The following is a description of a gene set: Mouse Gene Set: SHIN_B_CELL_LYMPHOMA_CLUSTER_8 Aside from Myc-activating translocations characteristic of plasmacytomas (PCT), little is known about genetic factors and signaling pathways responsible for the development of spontaneous B-cell lineage lymphomas of mice. Here, we characterized the transcriptional profiles of PCT, centroblastic diffuse large B-cell lymphomas (CBL), and high-grade splenic marginal zone B-cell lymphoma (MZL++) using high-throughput quantitative reverse transcription-PCR. Expression profiles of CBL and MZL++ were strikingly similar and quite unlike that of PCT. Among the genes expressed at significantly higher levels by PCT were a number involved in NOTCH signaling, a finding supported by gene set enrichment analyses of microarray data. To investigate the importance of this pathway, NOTCH signaling was blocked in PCT cell lines by treatment with a gamma-secretase inhibitor (GSI) or transduction of a dominant-negative mutant of MAML1. These treatments resulted in reduced expression of NOTCH transcriptional targets in association with impaired proliferation and increased apoptosis. GSI treatment of transformed plasma cells in a primary PCT also induced apoptosis. These results integrate NOTCH activation with oncogenic signaling pathways downstream of translocated Myc in the pathogenesis of mouse PCT, two signaling pathways also implicated in development of human multiple myeloma and T-cell lymphoblastic lymphoma. species: Mus musculus from publication Shin DM, Shaffer DJ, Wang H, Roopenian DC, Morse HC 3rd (PMID 19010892) Cluster 8 of genes distinguishing among different B lymphocyte neoplasms., and this is the list of marker genes: Cd38, Nfkbia, Smad7, Tyrobp, Spi1 (NCBI Gene Id 20375), Spn, Ccnb1, Stat1, Lmo1, Hdac1, Mafb, Itgam, Cdk2, Mfng, Il1r2, Il21r, Nbn, Snai1, H2ax, Gnas, Fancg, Tnfrsf13c, Lyn, Sox4, Cd80, Nfkbib, Fasl, Mapk3, Chek1, Il15, Il2ra, Ccnb2, Fas, Icam1, Wnt3a, Mafk, Psen1